Given this list of marker genes PIAS3 (NCBI Gene Id 128075), UBE3A, LRRK2, DBN1, NEDD4 (NCBI Gene Id 4734), KIF5B, PIAS1, STXBP1, USP14, BAIAP2, PNKD, GNAQ, CALM2, FUS, SUMO1, PPT1, PRKCG, PLCB3, SENP7 (NCBI Gene Id 57337), CALB1, CALM1, UBE2I, FBXO45, C9orf72, PRKCB, HTT, DAG1, HOMER1, SENP1, PLCB1, CALM3, GDI1, FABP5, SENP5, KIF5C, KIF5A, PIN1, SUMO2, ARL6IP5, SH3GL2, SYT1, here is a description of the gene set: Human Gene Set: GOCC_CYTOSOLIC_REGION Any (proper) part of the cytosol of a single cell of sufficient size to still be considered cytosol. species: Homo sapiens